The following is a description of a gene set: Human Gene Set: HP_PERICARDIAL_EFFUSION species: Homo sapiens Pericardial effusion Accumulation of fluid within the pericardium., and this is the list of marker genes: MYBPC3, CLCNKB, SAT1, PRKAG2, ENPP1, AEBP1, SLC12A3, UQCRFS1, EPHB4, CCBE1 (NCBI Gene Id 147372), SMAD4, PLVAP, SPP1 (secreted phosphoprotein 1), DPH5, LETM1, ITK, ABCC6, LMNA, GBA1 (NCBI Gene Id 82008), ABCC9, TCTN2 (tectonic family member 2), DNASE1L3 (deoxyribonuclease 1L3), ADAMTS3, ACADVL, PPP1R13L, PMM2, MYRF, BLTP1, EIF2AK4, TSC1, MTO1, ALG9, TSC2, PTPN14, MCM10, FAT4, RNU7-1, IRAK1, LYST, CDH23, HLA-DRB1, STAT4, IFIH1, MAF, CALCRL